The following is a description of a gene set: studied in species Homo sapiens mouse primary BMDCs were stimulated with tlr ligands and gene expression changes were profiled on Affymetrix arrays Genes down-regulated in comparison of control dendritic cells (DC) at 2 h versus those stimulated with Pam3Csk4 (TLR1/2 agonist) at 2 h. from publication Amit I, Garber M, Chevrier N, Leite AP, Donner Y, Eisenhaure T, Guttman M, Grenier JK, Li W, Zuk O, Schubert LA, Birditt B, Shay T, Goren A, Zhang X, Smith Z, Deering R, McDonald RC, Cabili M, Bernstein BE, Rinn JL, Meissner A, Root DE, Hacohen N, Regev A (PMID 19729616) Human Gene Set: GSE17721_CTRL_VS_PAM3CSK4_2H_BMDC_DN, and this is the list of marker genes: PRDX1, PTGR3, AMHR2, NUP54, ZBTB11-AS1, EDN1, SYT4, CSF2, ACOT1, RASA2, TBX1, MTTP, CLRN3, THOC1, LIF, CBX4 (NCBI Gene Id 8535), NPDC1, STARD4, OPN1SW, MMP17, SNTG2, LCT, GUCA2A (NCBI Gene Id 2980), CBY2, SOCS4, RARB, FLNB, SSTR2 (NCBI Gene Id 6752), IRX3, CYS1, KCNU1, TPX2, UCP3, KCND2, GNAT2, TRHR (NCBI Gene Id 7201), PPP1R14A (NCBI Gene Id 94274), WIPI1, DOCK6, MED21, OSGIN2, NDN, RTL8C, ATL3, PCSK4, RIBC1, ICOSLG, RNF2, SLC31A1, AFF4, FLG, MMD, DTNB, LTBP4, TPBG, DNAJC1, GSPT2, TTC39C, EQTN, ZBTB16, BEX1, IRS2, PECAM1, H1-8, HILPDA, IQSEC1 (NCBI Gene Id 9922), CXCL10, NOL6, IFT88, HEY1 (hes related family bHLH transcription factor with YRPW motif 1), CYP3A43, CFLAR, ETS2, SIX2, SLC4A5, ADAM12, PTPRA, PARP14, PAPLN, TNFSF9, TRAF5, CYP51A1, CDK5R2, DSCAML1, HAP1, AKR1B15, HSD17B2 (hydroxysteroid 17-beta dehydrogenase 2), PRKD1, GSC, KLHL13, LGALS2, SLC41A2, TMPRSS11D, FBXO33, TSPAN33, TOP1, DMTF1 (NCBI Gene Id 9988), LRRK2, PIK3R1, MYF5, CRIPTO, PLCG1, PTX3, MT3, SLFN12L, DNTT (DNA nucleotidylexotransferase), SERPINA12, PLAAT1, EPHX2, CDR2, SLC16A4 (NCBI Gene Id 9122), SOD2, HIGD1B, HTR7, TMEM39A, PTP4A3, LIMD1, SEC13, ST3GAL5, RNF11, TOMM22, HSP90AA1, BEX3, RAD23B, ANXA7, RPS6KA2, MTPN (NCBI Gene Id 94351), CD70, USP47, CARTPT, PRSS22, ZP2, PTGDR2, PRKCQ, SFXN4, EN1, MSX2, ATOH1, IL17RE, GABRG1, RNF19B, NYNRIN, PLSCR1, IL1RN, MAP3K6, SNX20, SERPIND1 (NCBI Gene Id 3053), MMP2, DDX19B, BCL10, GTF2A1L (NCBI Gene Id 11036), KRT12, MST1R, CLEC4E, GLIS1, SPECC1, ARHGEF3, REPIN1, IGFBP3, SLC22A23, SYT7, SYNGR4, MTF2, SLC38A4, SHC1, CLYBL, FANCG, DNAJC3, CD44, UBE2J2, CEP85, IFT122, PILRA, ATP6V0A4, SPIN4, SPN, NTHL1, BHLHE40, ITPKB, ARID5B, EHD1, EDNRA, WWOX, BLOC1S4, SFTPA1, B3GNT2, PROM2, WNT2B, CRISP2, PARD6B, PTGS2, COL12A1, AHCTF1, MACROD1, GRHPR, SAMSN1, CP, SCRT1, PUS1, USP9X